The following is a description of a gene set: Human Gene Set: HP_GENETIC_ANTICIPATION A type of autosomal dominant inheritance involving a gene that exhibits anticipation, the increase in severity and/or an earlier age of onset in subsequent generations. species: Homo sapiens Genetic anticipation, and this is the list of marker genes: ATN1, CACNA1A, ATXN3, ATXN10, SPAST, TERT, ATXN2, ATXN7, ATXN1